Given this list of marker genes Adrb2, Mapk1, Sphk1, Nol3, Vim, Ppp1cc, Stat3, Clec12b, Cadm4, Ppp1r9a (protein phosphatase 1, regulatory subunit 9A), Mapk8, Mtmr3, Smg7, Cdc5l, Ppp1r27, Fcrl6, Igbp1, Map3k5, Lck, Myo16, Ap3b1, Ceacam1, Bad, Iqgap1, Irs2, Lgals3, Ppp1r3c, Hsf4, Akap6, Cdh2, Flt4, Lmna, Trpc4ap, Drd1, Spred1, Cdc5lrt1, Mvp, Cd33, Nek2 (NCBI Gene Id 98226), Lilrb4b, Ctsc, Pxn, Rack1, Ppp1r3d, Ptk2, Csf1r, Lilrb4a, Ank1, Ncam1, Pirb, Sptbn4 (spectrin beta, non-erythrocytic 4), Cdc5lrt5, Atp2b4, Terf2ip, Chchd3, Foxo1, Adissp, Clec12a, Ppp1r36 (protein phosphatase 1, regulatory subunit 36), Cdh1, Eif2ak3, Akt1, Stat6, Cdkn1b, Dlg4, Met, Ppp1r15a (protein phosphatase 1, regulatory subunit 15A), Ros1, Ctnnd1, Strn, Cdc5lrt6, Sbf2, Map2k7, Akap5, Fbxl2, Sirpa, Wnk1, Syk, Ppp1r9b, Ppp2r2a, Cd300a, Magi2, Pecam1, Cry1, Cep192, Itga1, Kifap3, Cdc5lrt10, Reg1, Cdc5lrt7, Cpd, Gck, Dzip3, Slc6a3 (NCBI Gene Id 13162), Traf3, Trp53, Mastl, Magi3, Phactr1, Akap11, Ghr, Dlg1, Cttnbp2nl, Phactr4, Anapc5, Ikbkb, Ppp1ca, Jup, Cacng8, Jak3, Gab2, Nfatc2, Cnst, Ptpa, Dlg2, Ppp6r2, Sh2d4a, Sytl2, Ppp1r10, Dab2ip, Tbk1, Ppp1r3f, Ppp1r3g, Fmr1, Fas, Pik3r2, Pawr, Dtnb, Anapc4, Ppp1r18, Ywhae, Kif3a, Sod1, Igbp1b, Cdc27, Smad3, Git1, Ppara, Slc9a1, Strn4, Cdc5lrt8, Tmem225, Jak1, Nherf1, Rpa2, Amph, Dynlt4, Gna12, Kat2a, Tsc2, Ceacam2, Ppp3cb, Cabin1, Pdlim4, Arpp19, Mfhas1, Ppp2ca, Pik3r1, Gtf2f1, Pabir1, Dtna, Vcp, Fer, Fcrl5, Csrnp2, Strn3, Ell, Cry2, Itpr1, Fcrl2, Bod1, Ptpn1, Ppp1r3e, Grin3a, Ppp3r2, Cfl1, Klre1, Mapk3, Ptprt, Kcnn4, Adcy8, Nptxr, Pstpip1, Ppp3r1, Smg5, Cdc5lrt9, Stat1, Ensa, Ppp1r3a, Rps6kb1, Hmgcr, Mtmr4, Hsp90aa1, Ppme1, Cacna1b, Eif4ebp1, Mapk14, Pard3, Akap1, Cd22, Grb2, Stau1, Ppp6r3, Sh3gl1, Vcan, Grin1, Insr, Hsp90b1, Skap1 (NCBI Gene Id 78473), Ppp1r3b, Stx17, Dlg3, Shoc2, Styxl1, Bcl2, Ambra1, Vrk3, Ppp1r11, Sh3yl1, Ctnnb1, Cdh5, Cdc5lrt4, Siglecg, Csk, Snx3, Sh3rf2, Mapt, Nherf2, Rcan3, Traf2, Ankle2, Egfr, Tprn, Mast2, Pparg, Ppp6r1, Kcnq1, Ppp1r35, Mtmr9, Smtnl1, Anapc7, Shc1, Pvrig, Sfi1, Cacna1c, Smad2, Saxo4, here is a description of the gene set: Mouse Gene Set: GOMF_PHOSPHATASE_BINDING Binding to a phosphatase. studied in species Mus musculus